The following is a description of a gene set: Genes positively differentially expressed in cell type: Mast cell upon treatment with cytokine: IL-1β in mouse lymph nodes in vivo. Mouse Gene Set: CUI_MAST_CELL_IL1B_RESPONSE_UP from publication Cui A, Huang T, Li S, Ma A, Pérez JL, Sander C, Keskin DB, Wu CJ, Fraenkel E, Hacohen N (PMID 38057668) species: Mus musculus Cytokines mediate cell-cell communication in the immune system and represent important therapeutic targets. A myriad of studies have highlighted their central role in immune function, yet we lack a global view of the cellular responses of each immune cell type to each cytokine. To address this gap, the authors created the Immune Dictionary, a compendium of single-cell transcriptomic profiles of more than 17 immune cell types in response to each of 86 cytokines (>1,400 cytokine-cell type combinations) in mouse lymph nodes in vivo. A cytokine-centric view of the dictionary revealed that most cytokines induce highly cell-type-specific responses. For example, the inflammatory cytokine interleukin-1β induces distinct gene programmes in almost every cell type. A cell-type-centric view of the dictionary identified more than 66 cytokine-driven cellular polarization states across immune cell types, including previously uncharacterized states such as an interleukin-18-induced polyfunctional natural killer cell state., and this is the list of marker genes: St3gal5, Lcp2, Gzmb, Tax1bp1, Pcyt1a, Glb1, Tpsab1, Il7r, Pdcd1lg2, Zfp53, Cadm3, Ifitm2, Cdkn1a